The following is a description of a gene set: species: Homo sapiens Up-regulated in CD4+ T lymphocytes after 4 h treatment with 100 nM TSA. Human Gene Set: MOREIRA_RESPONSE_TO_TSA_UP from publication Moreira JM, Scheipers P, Sørensen P (PMID 14606959) BACKGROUND: Histone deacetylase inhibitors (HDACIs) induce hyperacetylation of core histones modulating chromatin structure and affecting gene expression. These compounds are also able to induce growth arrest, cell differentiation, and apoptotic cell death of tumor cells in vitro as well as in vivo. Even though several genes modulated by HDAC inhibition have been identified, those genes clearly responsible for the biological effects of these drugs have remained elusive. We investigated the pharmacological effect of the HDACI and potential anti-cancer agent Trichostatin A (TSA) on primary T cells. METHODS: To ascertain the effect of TSA on resting and activated T cells we used a model system where an enriched cell population consisting of primary T-cells was stimulated in vitro with immobilized anti-CD3/anti-CD28 antibodies whilst exposed to pharmacological concentrations of Trichostatin A. RESULTS: We found that this drug causes a rapid decline in cytokine expression, accumulation of cells in the G1 phase of the cell cycle, and induces apoptotic cell death. The mitochondrial respiratory chain (MRC) plays a critical role in the apoptotic response to TSA, as dissipation of mitochondrial membrane potential and reactive oxygen species (ROS) scavengers block TSA-induced T-cell death. Treatment of T cells with TSA results in the altered expression of a subset of genes involved in T cell responses, as assessed by microarray gene expression profiling. We also observed up- as well as down-regulation of various costimulatory/adhesion molecules, such as CD28 and CD154, important for T-cell function. CONCLUSIONS: Taken together, our findings indicate that HDAC inhibitors have an immunomodulatory potential that may contribute to the potency and specificity of these antineoplastic compounds and might be useful in the treatment of autoimmune disorders., and this is the list of marker genes: SELPLG, CD6, PA2G4, BAK1, MIF, TGFB1, ENO2, YWHAH, HSPA1A, HMGN1, PSMB4, BYSL, MYC, IGFBP4, BHLHE40, SSR4, CD82, HSP90AB1, USF2 (upstream transcription factor 2, c-fos interacting), CD2, FKBP4, EIF4A1, HSPA1B, RARA (NCBI Gene Id 5914), TP53, TMSB4X, EIF6, COX8A